Given this list of marker genes TSR1, MBNL1, DSPP, PAPOLA, DHX9, CCDC28B, DDX51, CORO7, RRP1, TRMU (tRNA mitochondrial 2-thiouridylase), ARL16, TSPAN3, WDPCP, MAP3K14, LANCL2, EPB41L4A, CDH18, SETD1B, RAB40B, UQCC5, LTO1, MEIOC, GIPC1, CIAO3 (NCBI Gene Id 82378), ALDH1L1, RHOBTB2, PHACTR2-AS1, SPOP, PELP1, HEATR5B, RRP9, ZNF530, TXNIP, NEK2-DT, THRAP3, ZSWIM9, SMARCC2, ZNF790-AS1 (NCBI Gene Id 284408), TTC9, CLPX, EBLN3P, GABPB1-IT1, POFUT1 (NCBI Gene Id 23509), ALKBH5, PDE4C, UCP3, MBTPS1, SCIN, TMEM14B, SESN1, EFCC1, MYO1C, NBPF10, ZNF559, NOXA1, ZNF502, SH2D3A, ADAM33, IGSF9B, U2AF2, CPAMD8, ZNF75A, JPX, CNNM3, PRKDC, ZFYVE27 (zinc finger FYVE-type containing 27), TMEM212, PER3, GTF2H3, SUN2, C14orf28, ZNF85, SARAF, CXCR4, CYTH1, CHIC1, MYH3, ADORA1 (adenosine A1 receptor), TRIM3, SMARCC1, WIZ, ZSCAN12, SCAF11, SSBP3-AS1, TSR3, FRG1JP, SH2B1, CHD2, HERC1, CABIN1, TBL3, ATP8B1, TCEAL4, GPATCH8, EEF1A2, XRCC2, POM121, CASS4, XRCC1 (NCBI Gene Id 7515), ANXA2P1, SENP7, LMBR1L, MEX3C, PIGA, TELO2 (telomere maintenance 2), FAAP24, ATP2B1, UNC5CL, FAM24B, HCFC1, UNK, GPR161, OSBPL5, EPHB6, DENND6A, ZNF793, DISP1, COX19, EP400 (E1A binding protein p400), DUSP2, KCNG2, PER1, BET1L, ARL17A, FAM118A, HDAC7, NPSR1-AS1, TMEM241, FAM53B, RHPN1, WDR55, DIP2A, PYGO2, ZNF37BP, ARRDC2, PACS1, TPCN2, HAUS2, SARM1, ZDHHC2, EWSR1, FBXW12, ARHGEF10L, ANKLE1, FBXW8 (NCBI Gene Id 26259), SCAF8, STAG3L1, ZNF677, CHERP, TCOF1, ESRRA, CUEDC1, ZNF329, PPIL2, DYRK1A, YJU2, CACTIN, XPC, ALMS1 (NCBI Gene Id 7840), ZNF671, UBQLN4, MAMDC4, LETM1, POFUT2, TAF1C, DCBLD2, RTN1, RBM27, COQ8A, PORCN, SMIM32, AMDHD1, DDX28, AMH, ZNF252P, ZNF430, ZNF91, LINC00623, QNG1, GPR25, ATP2B1-AS1, ATM, RBBP6, MEF2D, DDX11L2, RTEL1, CACNA2D3, ZNF286A, here is a description of the gene set: Human Gene Set: GSE45365_HEALTHY_VS_MCMV_INFECTION_CD11B_DC_UP Genes up-regulated in ITGAM+ dendritic cells: control versus primary acute viral infection. Murine Cytomegalovirus (MCMV) infection leads to early activation of various immune cells, including B and T lymphocytes, before the actual initiation of antigen-specific adaptive immunity. This activation is partly driven by innate cytokines, including type I interferon (IFN), which are induced early after infection. The objective of this study was to address the role of type I IFN in shaping early/innate B and T cell responses to a primary acute viral infection. In order to decipher the specific impact of IFN-I on cell subsets, we performed a genome-wide expression analysis on WT splenic B and CD8 T lymphocytes isolated from C57BL/6 mixed bone marrow chimera mice. This study complements series GSE39555, which focused on early responses of NK cells and of the two subsets of conventional dendritic cells. species: Homo sapiens